The following is a description of a gene set: Human Gene Set: GOBP_REGULATION_OF_RESPONSE_TO_TYPE_II_INTERFERON studied in species Homo sapiens Any process that modulates the rate, frequency or extent of a response to type II interferon (interferon-gamma). Response to interferon gamma is a change in state or activity of a cell or an organism (in terms of movement, secretion, enzyme production, gene expression, etc.) as a result of an interferon-gamma stimulus., and this is the list of marker genes: NR1H3, TXK, MED1, PPARG, CDC37, ARG1, OTOP1, DNAJA3, NLRC5, PARP14, PARP9, IRGM (NCBI Gene Id 345611), NR1H2, PTPN2, HPX